The following is a description of a gene set: Any process that results in a change in state or activity of a cell or an organism (in terms of movement, secretion, enzyme production, gene expression, etc.) as a result of a camptothecin stimulus. studied in species Mus musculus Mouse Gene Set: GOBP_RESPONSE_TO_CAMPTOTHECIN, and this is the list of marker genes: Spidr, Fancb, Blm, Recql5, Rad51